The following is a description of a gene set: Human Gene Set: REACTOME_JNK_C_JUN_KINASES_PHOSPHORYLATION_AND_ACTIVATION_MEDIATED_BY_ACTIVATED_HUMAN_TAK1 JNK (c-Jun kinases) phosphorylation and activation mediated by activated human TAK1 species: Homo sapiens, and this is the list of marker genes: IRAK1, RPS27A, NOD2, UBC, UBA52, MAPK8, IRAK2, UBE2V1, RIPK2, TAB1, TRAF6, MAPK9, UBB (ubiquitin B), TAB2, IKBKG, MAPK10 (NCBI Gene Id 5602), MAP2K7, UBE2N (ubiquitin conjugating enzyme E2 N), NOD1, TAB3, MAP2K4, MAP3K7